Given this list of marker genes GPR21, OR1C1, ADRA1A, GPER1, ADRB3, CHML, GPR6, CCKBR (cholecystokinin B receptor), MC5R, OR2F1, GPR174, OPRK1, ADRA1B (adrenoceptor alpha 1B), GPR173, HCAR3 (hydroxycarboxylic acid receptor 3), NMUR2, NTSR1, LHCGR (NCBI Gene Id 3973), SSTR1, OR7A10, P2RY4, HCAR1 (NCBI Gene Id 94013), OR11A1, MC1R, OR3A3, PRLHR (NCBI Gene Id 9347), CXCR1, RGL4, NPY1R, OR1Q1 (NCBI Gene Id 26729), CHRM1, FPR2, CCR4, NPY4R, GPR87, GPR20, GPR31, CCR9, OR7C2, FPR3, OR10J1, OR1D5, SSTR4, CNR2, CCR2, NPY2R, CCR7 (C-C motif chemokine receptor 7), P2RY12, NPBWR2, OR3A1, F2R, OR1G1, OPRM1, OR14J1, FSHR, P2RY10, OPN1SW, GPR63, OR8D2, NPFFR1, CCR3, OPN1MW, LPAR4, XCR1, GPR18, HCRTR1, CHRM2 (NCBI Gene Id 1129), OR1E2, GPR25, MC4R, OR8B8 (NCBI Gene Id 26493), HRH1, NMBR, OPN4, HTR1F, CHRM4, GPR39, AGTR1, GPR35, ADRB1, MLNR, PTGFR, HTR5A, TBXA2R, NMUR1, FFAR3, HTR1B, OR12D3, CXCR4, P2RY11 (NCBI Gene Id 5032), ACKR2, AGTR2, HTR2C, FFAR2, HTR1E, OR2J3 (olfactory receptor family 2 subfamily J member 3), OR1F1, MCHR1, OR7C1 (NCBI Gene Id 26664), OR2AG1, P2RY13, FFAR1, CHRM3, MC3R, GPR3, HTR2A, OR2S2, GPR19, GPR85, F2RL1, ADORA2A, CCR8, OR7A5, OXTR, NPY5R, OR2B6, OR7A17, OR2J2, HTR7, OR2H2, GPR42, ADORA3, C3AR1, HRH3 (histamine receptor H3), GPR32, LPAR6, HTR6, GALR3, EDNRB, OR10A5, OR6A2, GPR50, ADORA1, OR2B2, NPFFR2, CNR1, HTR1A, GPR37, OR2H1, GPR37L1, PTGER2, RHO, OR2J1, PTGDR2, OR10A4, P2RY14, HTR1D, PTAFR, GPR161, MAS1, TRHR, SUCNR1, OR10H2, NPY6R, GPR22, GPR171, MAS1L, PTGER4, OR1D4, PTGDR, NPBWR1, CXCR2 (NCBI Gene Id 3579), GPR65, P2RY2, OR2C1, CCR5, GPR75, GPR52, CXCR3, GRPR, GPR12, GPR17, CCR1, GPR45, MTNR1A, HRH2, OR1A2, CX3CR1, CYSLTR2, ACKR4, PTGER1, OR2A4, GPR4, GPR15, OPN3 (NCBI Gene Id 23596), OR5F1, OR10H1, EDNRA, OR1E1, OPN1LW, LPAR5, AVPR1A, NTSR2, MC2R, OR5I1, GPR27, OR1D2, F2RL3, DRD4, LTB4R, OR6B1, C5AR2, RRH, CCKAR, GPR34, GHSR, CCRL2, APLNR, OR2D2, GALR2, CCR6, CXCR5, ADRA2C, OR1I1, OR2B3, ADRA1D, BDKRB2, OR1A1, AVPR2, OPRD1, CYSLTR1, ADRA2B, HTR4, AVPR1B, FPR1, ADRB2, PTGER3, SSTR3, CCR10, OPRL1, OR5V1, ADORA2B, CHRM5 (cholinergic receptor muscarinic 5), DRD3, HCRTR2, HTR2B, OR2T1, GPR83, GALR1, F2RL2, DRD2, CMKLR1, PTGIR, OR10H3, BDKRB1, DRD5, BRS3, SSTR2, DRD1, OR2F2, CMKLR2, OR2W1, P2RY1, GPR68, MTNR1B, OR3A2, ACKR3, ADRA2A, SSTR5, P2RY6, here is a description of the gene set: GPCRs, class A rhodopsin-like Human Gene Set: WP_GPCRS_CLASS_A_RHODOPSINLIKE species: Homo sapiens